The following is a description of a gene set: Mouse Gene Set: GOBP_NUCLEOTIDE_SUGAR_METABOLIC_PROCESS The cellular chemical reactions and pathways involving nucleotide-sugars, any nucleotide-carbohydrate in which the distal phosphoric residue of a nucleoside 5'-diphosphate is in glycosidic linkage with a monosaccharide or monosaccharide derivative. studied in species Mus musculus, and this is the list of marker genes: Gfus, Guk1, Gmds, Uap1, Uap1l1, Entpd5, Gmppa, Amdhd2, Slc2a1, Uxs1, Pgm3, Fcsk, Tgds, Cmah, Extl2, Slc35c1, Fpgt, Uggt1, Slc35a1, Pmm2, Gnpda1, Gnpnat1, Ugp2, Hk1, Fuom, Galt, Gfpt1 (glutamine fructose-6-phosphate transaminase 1), Fut8, Pmm1, Gnpda2 (NCBI Gene Id 71118), Gmppb, Nanp, Ugdh, Gne, B4galnt2, Parg, Csgalnact1, Gfpt2, Nans, Mpi, B3galnt2, Dpm1, Dpagt1, Cmas, Mgat1